The following is a description of a gene set: studied in species Homo sapiens Any process that increases the frequency, rate or extent of centrosome duplication. Centrosome duplication is the replication of a centrosome, a structure comprised of a pair of centrioles and peri-centriolar material from which a microtubule spindle apparatus is organized. Human Gene Set: GOBP_POSITIVE_REGULATION_OF_CENTROSOME_DUPLICATION, and this is the list of marker genes: CEP295, ROCK2, NPM1, CEP120, POC1A